Given this list of marker genes CBX6, CBX7, SAMD11, RNF2, PCGF3, SAMD7, CBX4, PCGF5, RING1, PHC3, PCGF2, PHC2, CBX2, CBX8, PCGF1, PCGF6, BMI1, PHC1, here is a description of the gene set: A multiprotein complex that mediates monoubiquitination of lysine residues of histone H2A (lysine-118 in Drosophila or lysine-119 in mammals). The complex is required for stable long-term maintenance of transcriptionally repressed states and is involved in chromatin remodeling. species: Homo sapiens Human Gene Set: GOCC_PRC1_COMPLEX